The following is a description of a gene set: C57Bl/6 wild-type and STAT6 KO mice were used to study PPARg and IL-4 signaling. Bone marrow of 3 mice per group was isolated and differentiated to macrophages with M-CSF (20 ng/ml). 20 ng/ml IL-4 was used to induce alternative macrophage activation and 1 uM Rosiglitazone (RSG) was used to activate PPARg. From each mouse 4 samples were generated: 1. M-CSF, 2. M-CSF+RSG, 3. IL-4 and 4. IL-4+RSG. All compounds were added throughout the whole differentiation process, and frech media was added every other day. Control cells were treated with vehicle (DMSO:ethanol). After 10 days, RNA was isolated and gene expression profiles were analyzed using Mouse Genome 430 2.0 microarrays from Affymetrix. Human Gene Set: GSE25088_WT_VS_STAT6_KO_MACROPHAGE_ROSIGLITAZONE_AND_IL4_STIM_UP studied in species Homo sapiens Genes up-regulated in bone marrow-derived macrophages treated with IL4 and rosiglitazone: wildtype versus STAT6 knockout. from publication Szanto A, Balint BL, Nagy ZS, Barta E, Dezso B, Pap A, Szeles L, Poliska S, Oros M, Evans RM, Barak Y, Schwabe J, Nagy L (PMID 21093321), and this is the list of marker genes: ACTR3B, TMEM143, SCRIB, SPC24, ZBTB22, SMARCA5, DOCK5, LAS1L, NHERF1, THBD, CWC27, NOSTRIN, CH25H, GRWD1, MEAF6, ANKRD54, MTR, TBC1D9, USH2A, C4orf46 (NCBI Gene Id 201725), SLC25A3, TOPBP1, ACLY, CLASP1, MARK4, PTPRB, KRT71, STC2, UGDH, CDCA3, COQ9, MRPL15, DLG3, DCTD, FAM220A, SLC35D1, IRF2BPL, DSC1, CX3CR1 (NCBI Gene Id 2836), PCGF6, CYP19A1, SUCLG1, ZC3H13, SPC25, RBL1, CCDC6, NUDT6 (NCBI Gene Id 11162), SLC17A7, DBF4, LXN, WEE1, SERPINE2, EIF4EBP2, SASS6, AGAP1 (ArfGAP with GTPase domain, ankyrin repeat and PH domain 1), SLC9A5, CHST11, ERI1, RETSAT, GGA2, TFEC, HIP1, CDK1, BICC1, KPNA2, XRCC3, PSIP1, RASA2, MTFR2, IL25, DPH7, ADAT1, POLE, CD81, RPL23A (ribosomal protein L23a), EMILIN2, NYX, N4BP1, MAOA, MRPL19, OXSR1, DHCR7, PRDM5, CTDSPL2, DYNC2I1, RCN2, ZMPSTE24, OOSP2, ICA1, PIK3CD, PFDN4, GALNT18, CENPE, MVB12B, FRRS1, GTF2F2, THAP4, DGCR8, PPM1F, HNRNPA3, STRN, PDCD6IP, LDAF1, NRAS, HACD1, GFM1, SLC2A8, WFDC5, CKAP4, CDC42EP5, CISD1, AKIP1, PRNP, FBXO46, DYNLT5, NSUN4 (NOP2/Sun RNA methyltransferase 4), B4GALNT4, EIF2S2, TFPI, MRPL46, SS18 (NCBI Gene Id 6760), DUSP22, RNF4, TNPO1, NME2, POC1B, ADGRL4, RAD54B, CEP126, PBK, FAHD2A, LAP3, KANSL3, DDX27, DAP3, AKR7A2, RALBP1, TIRAP, SNAPC2, EMC1, MMS22L, SNX7, SLC19A2, UBALD2, SNHG7, CCDC102A, SNHG6, KCP, SLC20A1, PTGIS, EPHB4, ANXA2, PRORP, SRRD, KMT5A, CMTM2, E2F8, WDR19 (NCBI Gene Id 80203), SHISA2, SF3A3, CDC45, RPS27L, NUBP2 (NUBP iron-sulfur cluster assembly factor 2, cytosolic), DDX20, SLC25A39, TACC3 (NCBI Gene Id 10460), TRIM28, ATAD3A, PEBP1, ENTPD5, PDHA1, HSD17B12, CIDEA, SLC48A1, ZDHHC18, PTH1R, GSPT2, STEAP3, COPS3, LRRC8D, CHD7, SAP30, RABL3, PCLAF, NEK4, CFDP1, SBNO2, CMPK1, ERAP1, NMT1, IPPK, SAR1A (secretion associated Ras related GTPase 1A), MFSD2A, NUCKS1, PITRM1, SPTLC3, TMEM238, HDGF (heparin binding growth factor), IPP (NCBI Gene Id 3652)